The following is a description of a gene set: species: Homo sapiens HDR through MMEJ (alt-NHEJ) Human Gene Set: REACTOME_HDR_THROUGH_MMEJ_ALT_NHEJ, and this is the list of marker genes: RAD50, PARP1, RAD52, NBN, XRCC1, LIG3, BRCA2 (BRCA2 DNA repair associated), FEN1 (flap structure-specific endonuclease 1), RBBP8, MRE11, PARP2, POLQ